The following is a description of a gene set: Human Gene Set: GOMF_MRNA_BASE_PAIRING_TRANSLATIONAL_REPRESSOR_ACTIVITY species: Homo sapiens A translation repressor activity that acts by base-pairing with an mRNA. The binding can result in targeting the mRNA for degradation or interfering with mRNA translation, hence resulting in posttranscriptional gene silencing., and this is the list of marker genes: MIR519D, MIR503, MIR511, MIR204, MIR17, MIR425, MIR519E, MIRLET7B, MIR362, MIR301B, MIR520D, MIR520B, MIR208B, MIR769 (NCBI Gene Id 768217), MIR410, MIR25, MIR194-1, MIR454, MIR211, MIR15B, MIR155, MIR181A2, MIR517C, MIR498, MIR508, MIR588, MIR3148, MIR202, MIR126, MIR190B, MIR4286, MIR517A, MIR214, MIR145, MIR92A1, MIR296, MIR302E, MIR136, MIR186, MIR154, MIRLET7A1, MIR23A, MIR544A, MIR514A1, MIR130A, MIR224, MIR15A, MIR125B1, MIR326, MIR106B, MIR10B, MIR103A1, MIR219A1, MIR1207, MIR449A, MIR4686, MIR302D, MIR455, MIR30A, MIR1224, MIR874, MIR302C, MIR22, MIR337, MIR339, MIR221, MIR520A, MIR206, MIR654, MIR141, MIR149, MIR32, MIR483, MIR877, MIR562, MIR299, MIR182, MIR92B (NCBI Gene Id 693235), MIR33B, MIR372, MIR107, MIR19A, MIR451A, MIR192, MIR329-1, MIR328, MIR18B, MIR564, MIR152 (NCBI Gene Id 406943), MIR10A, MIR3173, MIR130B, MIR135A1, MIR346, MIR153-1, MIR93, MIR340, MIR210, MIR6869, MIR34C, MIR518A1, MIR582, MIR657, MIR448, MIRLET7I, MIRLET7E, MIR487B, MIR217, MIR135B, MIR30C1, MIR424, MIR374B (NCBI Gene Id 100126317), MIR323A, MIR4516, MIR1298, MIR26A1 (NCBI Gene Id 407015), MIR1908, MIR133B, MIR335, MIR876, MIR374A, MIR1271, MIR526A1, MIR1260B, MIR1-1, MIR320A, MIR365A, MIR345, MIR148A, MIR103B1, MIR301A, MIR363, MIR492, MIR509-1, MIR411, MIR187, MIR302A, MIR607, MIR572, MIR105-1, MIR892B, MIR376C, MIR142, MIR29B1, MIR373, MIR767, MIR193A, MIR659, MIR4691, MIR20A, MIR551A, MIR139 (microRNA 139), MIR520C, MIR183, MIR28, MIR9-1, MIR499A, MIR132, MIR151A, MIR30C2, MIR127, MIR644A, MIR640, MIR497, MIR98, MIR188, MIR196A1, MIR140, MIR758, MIR137, MIR181C, MIR378A, MIR3619, MIR6086, MIR21, MIR133A1, MIR429, MIR212, MIR518C, MIR873, MIR379, MIR208A, MIR181B1, MIR708, MIR150, MIR590 (microRNA 590), MIR24-1, MIR33A, MIR146B, MIR199B, MIR548C, MIR138-1, MIR101-1, MIR613, MIR520E, MIR519A1, MIR939, MIR200C, MIR148B, MIR384, MIR1277, MIR543, MIR27B, MIR548P, MIR27A, MIR181D, MIR193B, MIR519B, MIR1246, MIR490, MIR99A, MIR920, MIR493, MIR205, MIR608 (microRNA 608), MIR29C, MIR639, MIR215, MIR573, MIR20B, MIR128-1, MIR223, MIR34A, MIR361, MIR655, MIR199A1, MIR491, MIR129-1, MIR31, MIR100, MIR650, MIR302B, MIR661, MIR675, MIRLET7C, MIR506, MIR330, MIR29A, MIR494, MIR548D1, MIR371A, MIR298, MIR5588, MIR663A, MIR191, MIR16-1, MIR125A, MIR203A, MIRLET7F1, MIR30D, MIR18A, MIR518B, MIR423, MIR218-1, MIR4632, MIR30B, MIR134, MIR96, MIR342, MIR3661, MIR19B1, MIR143, MIR625, MIR488, MIR505, MIR30E, MIR144, MIR3909, MIR338 (NCBI Gene Id 442906), MIR383, MIR4500, MIR486-1, MIR485 (NCBI Gene Id 574436), MIR200B, MIR34B, MIR885, MIR501 (microRNA 501), MIR495, MIRLET7G, MIR146A, PTENP1-AS, MIR2355, MIR1181, MIR222, MIR195, MIR106A, MIR26B, MIR185, MIR665, MIR99B, MIR520H, MIR638, MIR552, MIR409, MIR515-1, MIR935, MIR200A, MIR147A